The following is a description of a gene set: species: Homo sapiens IL10 anti-inflammatory signaling Human Gene Set: WP_IL10_ANTIINFLAMMATORY_SIGNALING, and this is the list of marker genes: IL1A (interleukin 1 alpha), IL10RB, IL10RA, STAT2, IL6, BLVRA, BLVRB, IL10, HMOX1, JAK1, STAT1, STAT3